The following is a description of a gene set: The known DNA methyltransferases (DNMT1, DNMT3A, and DNMT3B) can be SUMOylated. SUMOylation affects the catalytic activity of DNMT1 and the protein interactions of DNMT3A. species: Homo sapiens Reactome Pathway: SUMOylation of DNA methylation proteins part of: SUMO E3 ligases SUMOylate target proteins, and this is the list of marker genes: RING1, PHC3, BMI1, CBX4 (NCBI Gene Id 8535), DNMT3A, PHC2, PHC1, PCGF2, RNF2, UBE2I, DNMT3B, CBX8 (chromobox 8), DNMT1, SUMO1, SCMH1, CBX2